Given this list of marker genes PDE9A, SLC16A2, NF1 (NCBI Gene Id 646021), TP53, GATA2, CEND1, VAX1, MIR137, SIRT2, NR2E1, APPL2, VSX2, PAX6, SPINT2, SHOC2, PTN, SLC6A4, TGFB1, KIFAP3, PROX1, SPINT1, KCTD11, BTG2, WNT5A, LIMS2, KDM2B, ILK, CTNNA1, here is a description of the gene set: species: Homo sapiens Human Gene Set: GOBP_NEGATIVE_REGULATION_OF_NEURAL_PRECURSOR_CELL_PROLIFERATION Any process that stops, prevents, or reduces the frequency, rate or extent of neural precursor cell proliferation.